The following is a description of a gene set: Abnormality of an amino acid metabolic process. species: Homo sapiens Human Gene Set: HP_ABNORMALITY_OF_AMINO_ACID_METABOLISM Abnormality of amino acid metabolism, and this is the list of marker genes: ERCC2, TAT (NCBI Gene Id 6898), ERCC5, ERCC4, CBS, AGA, SLC30A10, ERCC3